The following is a description of a gene set: A shift from the normally round (convex) appearance of the iliac wing towards a square-like appearance. Squared iliac bones Human Gene Set: HP_SQUARED_ILIAC_BONES studied in species Homo sapiens, and this is the list of marker genes: LONP1, MATN3 (matrilin 3), INPPL1 (inositol polyphosphate phosphatase like 1), TRPV4, NEPRO, COG1, PTH1R, PAM16, GNPNAT1, RNU4ATAC, AEBP1, CEP120, HSPG2, PLCB3